Given this list of marker genes Klf4, Klf2, Xbp1, Ass1, Mapk7, Nfe2l2, here is a description of the gene set: Mouse Gene Set: GOBP_CELLULAR_RESPONSE_TO_LAMINAR_FLUID_SHEAR_STRESS Any process that results in a change in state or activity of a cell (in terms of movement, secretion, enzyme production, gene expression, etc.) as a result of a laminar fluid shear stress stimulus. Laminar fluid flow is the force acting on an object in a system where the fluid is moving across a solid surface in parallel layers. species: Mus musculus